The following is a description of a gene set: species: Homo sapiens Human Gene Set: GOBP_LEUKOCYTE_ACTIVATION_INVOLVED_IN_INFLAMMATORY_RESPONSE A change in the morphology or behavior of a leukocyte resulting from exposure to an activating factor such as a cellular or soluble ligand, leading to the initiation or perpetuation of an inflammatory response., and this is the list of marker genes: MIR142, JAK2, IL33, CX3CR1, IFNGR2, TYROBP, MIR128-1, C1QA, TREM2, IL6, GRN, CTSC, TLR6, MAPT, KCNJ8, SYT11, SCNN1B, TTBK1, SPHK1, IL13, FPR2, LRRK2, CLU, TRAF3IP2, MIR181C, SNCA, CST7 (cystatin F), TLR3, MMP8, LDLR, AIF1, TLR9, TLR1, NR1D1, JUN, ITGAM, C5AR1 (NCBI Gene Id 728), APP, IFNGR1, TNF, MYD88, CCL3, IFNG, CALHM2, STAP1, AZU1, ITGB2, NAGLU, CX3CL1, AGER, PTPRC, TAFA3